Given this list of marker genes CCND2, RAB23, CAB39, PJA2, PRLR, PPP1R1B, LRP1B, HSF5, BTAF1, KRTAP13-1, STEAP4, LPGAT1, CUL3, ASXL3, TDRKH, BMPR2 (NCBI Gene Id 659), KLF3, EIF3CL, DAZ1, WNT8A, UHMK1, ACBD5, UGGT1, ADAM22, PPARG, DAZL (NCBI Gene Id 1618), PARP8, EIF3C, SLC16A9, PALLD, GNAI1, BCAT1, KDM2A, PRKACB, RPF2, HIPK1, TMEM67, SNX4, HASPIN, NEXMIF, VWA8, IQCH, GPR85, ABHD10, DCTN6, DUSP11, SLC25A12, DAZ4, CAPNS2, MAPK9, KCNV1, PIP4K2C, UMAD1, MXI1, RNF135, HEATR1, TFAP2D, TPX2, HNRNPR, ARHGEF35, ATXN7L1, TET3, UCHL1, SORBS2, ARMCX3, PKP4, DAZ2, DCUN1D5, NAA40, PDGFRA, LRP2, CNTNAP5, BMP2K (NCBI Gene Id 55589), MSR1, PFN2, YAP1, EPHA3, SPIN4, TMEM144, PIK3AP1, PPP2R2D, C1GALT1C1, CELF1, IRS1, ABTB3, RMI1, GMFB, DLEU7, DNM3, PCDH19 (NCBI Gene Id 89774), ERGIC2, CYP2C19, DAZ3 (NCBI Gene Id 57054), TNF, here is a description of the gene set: Human Gene Set: MIR3617_3P Genes predicted to be targets of miRBase v22 microRNA hsa-miR-3617-3p in miRDB v6.0 with MirTarget v4 prediction scores > 80 (high confidence targets). studied in species Homo sapiens from publication Chen Y, Wang X (PMID 31504780)